The following is a description of a gene set: studied in species Mus musculus Cytokines mediate cell-cell communication in the immune system and represent important therapeutic targets. A myriad of studies have highlighted their central role in immune function, yet we lack a global view of the cellular responses of each immune cell type to each cytokine. To address this gap, the authors created the Immune Dictionary, a compendium of single-cell transcriptomic profiles of more than 17 immune cell types in response to each of 86 cytokines (>1,400 cytokine-cell type combinations) in mouse lymph nodes in vivo. A cytokine-centric view of the dictionary revealed that most cytokines induce highly cell-type-specific responses. For example, the inflammatory cytokine interleukin-1β induces distinct gene programmes in almost every cell type. A cell-type-centric view of the dictionary identified more than 66 cytokine-driven cellular polarization states across immune cell types, including previously uncharacterized states such as an interleukin-18-induced polyfunctional natural killer cell state. from publication Cui A, Huang T, Li S, Ma A, Pérez JL, Sander C, Keskin DB, Wu CJ, Fraenkel E, Hacohen N (PMID 38057668) Mouse Gene Set: CUI_T_CELL_GD_DECORIN_RESPONSE_DN Genes negatively differentially expressed in cell type: γδ T cell upon treatment with cytokine: Decorin in mouse lymph nodes in vivo., and this is the list of marker genes: Hspa8, Hspa5, Junb, Ppp1r15a, Nr4a1, Uba52, Fos